Given this list of marker genes DDB1, STK35 (serine/threonine kinase 35), KIT, ZFPM2, IGF1, OVGP1, CDKN1B, NODAL, TRIP13, ZWINT, FBXO43, NKX3-1, WNT4, NLRP5 (NLR family pyrin domain containing 5), ASTL, PRDX4, OVOL1, EAF2, PLAT, GPR149, HORMAD1, ACVR1C, SERPINF1, BMP7, TIMP1, ZP2 (NCBI Gene Id 7783), PTGDS, SEMG2, RPS6KA2, PAEP, MYH9, PKMYT1, UBE2B, STK11, MAEL, EPPIN, YBX3, NANOS2, FBXO5, KNL1, TEX11, DUSP1, WT1, NPR2, CHFR, BMP4, HPGDS, ARHGDIB, BCL2L1, NR5A1 (NCBI Gene Id 2516), MIR16-1, SPINK13, WNT5A, WDR77, ADA, CALR, TPST2, PTGDR2, GJA1, SULF1, MIR15B, LIF, ZP4, SNAI1, ZP1, SEMG1, NPPC, SHB, WEE2, TTK, SOD1, DMRT1, PDIK1L, RAD1, MOS, SYCP2, ELF5, ZP3, here is a description of the gene set: Any process that stops, prevents, or reduces the frequency, rate or extent of reproductive process. species: Homo sapiens Human Gene Set: GOBP_NEGATIVE_REGULATION_OF_REPRODUCTIVE_PROCESS